The following is a description of a gene set: The process in which the anatomical structures of the epidermis are generated and organized. The epidermis is the outer epithelial layer of an animal, it may be a single layer that produces an extracellular material (e.g. the cuticle of arthropods) or a complex stratified squamous epithelium, as in the case of many vertebrate species. studied in species Mus musculus Mouse Gene Set: GOBP_EPIDERMIS_MORPHOGENESIS, and this is the list of marker genes: Gorab, Intu, Naglu, Flg2, Sostdc1, Tfap2a, Tgfb2, Trp63, Notch1, Wnt10a, Smo, Tmem79, Pla2g10, Shh, Ctsl, Fst, Dsc1, Runx3, Krt17, Ngfr, Plod3, Krt25, Fgf7, Foxq1, Ctnnb1, Atp7a, Smarca4, Lamc1, Klf4, Fgf10, Gli2, Foxe1, Klk14, Igfbp5, Krt28, Ext1, Krt71, Fgfr2, Runx1, Gsdma3, Snai1, Dlx3, Bcl2, Dicer1, Krt27